The following is a description of a gene set: Human Gene Set: GOBP_REGULATION_OF_CARDIAC_MUSCLE_CONTRACTION_BY_CALCIUM_ION_SIGNALING Any process that modulates the frequency, rate or extent of cardiac muscle contraction by changing the calcium ion signals that trigger contraction. species: Homo sapiens, and this is the list of marker genes: JPH3, ATP2A2, GSTM2, NOS1, ASPH, SLC9A1, TRDN, CLIC2, JPH2, TNNI3, CAMK2D, MIR1-1, CACNA1C, SLC8A1 (NCBI Gene Id 6546), RYR2, CASQ2, CALM1, JPH1, ATP1A2, MIR133A1, GSTO1, PRKACA, JPH4, FKBP1A, CALM3, ANK2, CALM2, PLN, HRC, TMEM38A, ATP1B1, TMEM38B, FKBP1B, DMD